The following is a description of a gene set: studied in species Mus musculus Female A/J mice received a single i.p. injection of N-methylnitrosourea (MNU) in acidified saline (pH 5.0) at a dose of 50 mg/kg body weight. Mouse Gene Set: YAO_AJ_MOUSE_LUNG_TUMOR_PROGRESSION_DIFFERENT_ADENOCARCINOMA_DN Genes detected by RT-PCR showing different changes in lung adenomas and lung adenocarcinomas. Tissue is from lung adenocarcinomas from female A/J mice. from publication Yao R, Wang Y, Lubet RA, You M (PMID 12173053), and this is the list of marker genes: Jun, Cdc42, Igfbp6, Ybx1, Bax (BCL2-associated X protein), Kdr, Tgfb2, Pecam1 (platelet/endothelial cell adhesion molecule 1), Fasl, Notch4, Pdgfa (platelet derived growth factor, alpha), Ace (NCBI Gene Id 11421)